The following is a description of a gene set: Human Gene Set: GOMF_ALPHA_2A_ADRENERGIC_RECEPTOR_BINDING Binding to an alpha-2A adrenergic receptor. studied in species Homo sapiens, and this is the list of marker genes: APLP1, GRK2, ADRA2C, ADRB1, UCHL1